The following is a description of a gene set: Mouse Gene Set: GOBP_HYPOTHALAMUS_GONADOTROPHIN_RELEASING_HORMONE_NEURON_DIFFERENTIATION studied in species Mus musculus The process in which a relatively unspecialized cell acquires specialized features of a neuron located in the hypothalamus. These neurons release gonadotrophin-releasing hormone as a neural transmitter., and this is the list of marker genes: Plxna3, Sema3e, Nrp2, Sema3a, Plxna1, Nhlh2, Nrp1, Ubb, Ndnf